Given this list of marker genes Mapk3 (NCBI Gene Id 26417), Ptbp1, Fgf4 (NCBI Gene Id 14175), Grb2, Spry2, Fgf20 (fibroblast growth factor 20), Polr2k, Polr2f, Fgf23, Fgf7, Ubb, Gtf2f1, Polr2b, Polr2e, Fgf8, Fgf10, Fgf16, Polr2i, Polr2l, Hras, Fgf2, Polr2a, Gab1, Frs2, Rps27a, Fgf6, Fgf22, Fgf1, Polr2c, Fgf17, Fgfbp3 (fibroblast growth factor binding protein 3), Cbl, Gtf2f2, Fgf5, Fgfbp1, Shc1, here is a description of the gene set: electronically inferred by orthology from the curated human pathway part of: Signaling by FGFR This event has been computationally inferred from an event that has been demonstrated in another species.<p>The inference is based on the homology mapping from PANTHER. Briefly, reactions for which all involved PhysicalEntities (in input, output and catalyst) have a mapped orthologue/paralogue (for complexes at least 75% of components must have a mapping) are inferred to the other species. Reactome Pathway: Signaling by FGFR2 studied in species Mus musculus